The following is a description of a gene set: species: Homo sapiens from publication Hu X, Park-Min KH, Ho HH, Ivashkiv LB (PMID 16148108) Genes up-regulated in macrophages primed and then stimulated by IFNG: 3h versus 24h. Human Gene Set: GSE1925_3H_VS_24H_IFNG_STIM_IFNG_PRIMED_MACROPHAGE_UP IFN-gamma transcriptional responses in control and IFN-gamma primed primary human macrophages, and this is the list of marker genes: TSEN15, PROS1, NIPSNAP2, ITGAL, EPHA2, RNF14, IKBIP, MAP3K12, PRDX4, ATP6V0B, DDHD2, ZRANB1, TYRO3, NGRN, CSNK2A1, CXADR, IMMP1L, TMEM230, ZNF22, KLHL7, RNF19A, PEG3, ITGA6, RAB4A, SLC7A7, HAL, AGRN, PKIA, CCNDBP1, TRABD, HSD11B1, COMMD5, GALNT11, JARID2 (jumonji and AT-rich interaction domain containing 2), AXIN2, TNFRSF18, GAB1, SYT9, SUCLG1 (succinate-CoA ligase GDP/ADP-forming subunit alpha), EPS8, PKD2, SATB1, EPHB6, DICER1, GNG10, KLF13, DDX19B, PLOD3, CDX2, S100A13, CLK2, CD3G, SRPK2, CELSR1, SETD4, NXF1, LMO4, RPTN, GAS8, GFER, LGALSL, PACRGL (parkin coregulated like), NFKBIA, ZFP14, TPMT, NDUFS2, TBC1D14, VCL, NEK1 (NIMA related kinase 1), ZBTB20, MCCC1, PSMB1, LTK, FAH, SLC66A3, MED1, CLDN1, KLF10, DNAAF10, PTTG1, C9orf85, ZNF23, MAPK10, MTM1, HARS1 (NCBI Gene Id 3035), BEX4, UBA5, WNT5B, CD3D, CST3, XPNPEP1, RETSAT, WLS, DPP7, ELOA, EVL (NCBI Gene Id 51466), DHRS3, ADPRH, LDHB, TMCO1 (transmembrane and coiled-coil domains 1), SLC26A2, FBP1, PBX3, DENND5A, TGDS, ZNF865, RTL6, ZNF354A, METAP2, CXCR4, HSBP1, SIGMAR1, JTB, ABCB10, ZNF600, NMRK1, PTP4A3, PAWR, CLEC16A, KIFAP3, INPPL1, SLC30A1, TRIM27, PPP1R21, GALT, KIF3A, ACYP1 (acylphosphatase 1), FOXD1, BTC, NUP50, SBF2, GSTK1, LIMD1, PFKM, TUBGCP4 (tubulin gamma complex component 4), CHCHD5, TBCE, PTGR1, CAPN3, DHRS7, RRAGD, DNASE1L1, RELL1, EMP1, MMP14, RBM39, TLR6, MMP11, CASP6, SLC44A1, SLC39A8, VCP, TRPV2 (NCBI Gene Id 51393), PADI4, FOXB1, CAPRIN2, DPP8, MAPRE1, TAGLN2, SMYD1, ADPRM, ZCCHC3, REEP1, SPIB, TMEM106C, WDR83OS, MRPL35, LSM14B, MAGED2, CCL25, HES5, NKIRAS1, CDR2L, CCNB1IP1, ACYP2, CDKN1A, NPL, SCG5, SPSB1, LAPTM4B, CNGA1, ANAPC16, ACP3, CXXC5, LGALS4, ENO2, GNB4, SGCB, RAB3D, ADGRG1, MCAM, C19orf12, ETAA1, MCL1, IQGAP1, ORM1, APIP, WDFY2, KDELR3, GLRX